The following is a description of a gene set: Human Gene Set: HP_BROAD_PHILTRUM Broad philtrum species: Homo sapiens Distance between the philtral ridges, measured just above the vermilion border, more than 2 standard deviations above the mean, or alternatively, an apparently increased distance between the ridges of the philtrum., and this is the list of marker genes: ARID1A, ERMARD, PIGW (NCBI Gene Id 284098), SCN1A, H3-3A, PGAP2, SMARCA2 (SWI/SNF related, matrix associated, actin dependent regulator of chromatin, subfamily a, member 2), AP2M1, SOX4, MAF, PIGO, PIGL, ZNF462, PIGV, NEXMIF, WDR35, CHD2, TBL1XR1, SMARCE1, COLEC11, RAC3, KCNK9, SYNGAP1, SOX11, FGD1, CDH11, SPTBN1, ROBO1, SMARCA4, ARID1B, SMARCB1, SMARCC2, DPF2, TAF4, AHDC1, KMT2D, TMCO1, SLC2A1, ALX4, PGAP3, SMARCD1, PIGY, SNX14, SLC6A1, ARID2, ANO1